Given this list of marker genes CXCR3, RHOF, FKBP5, CNGB1, NR2F2, HINFP, ARFGEF3, AK2, SYT7, ABHD5, UNC5B, CHRNE, FANCC, SEMA4G, BCL2L1, CALN1, SLC24A4, ATF5, ECE1, ATF7, TET3, IER5, RALY, C19orf47 (chromosome 19 open reading frame 47), BRWD1 (NCBI Gene Id 54146), GUCA1C, PPP1R18, EI24, ZCCHC3, RPL15, VWA1 (NCBI Gene Id 64856), CTNND1, DYNLT3, TMEM127, PDYN, VTI1A, PKNOX2, CBX4, CHRNB2, DDN, SPAG7, KCNA1, FCER1G, KIAA0319, RNF14, PBX2, ATXN7L3, SELENOW, PI4KB (phosphatidylinositol 4-kinase beta), RAB3A, USB1, CSNK1G1, IPCEF1, MAPK10, CNTNAP3, FOXRED1, ZNF346, HOXD13, CALU, MFN1, TMOD2, DMTN, P2RY4, AMFR, ARHGEF7, KDM4A, THRA, NAA40, PXN, HOXB9, SAMD4B, DPP8, RUFY2, CNTNAP3B, MAZ, PRDM11, SCRT2, TMEM121B, MYO1E, DCHS2, LRRTM2, CERT1, MKLN1 (muskelin 1), MMRN2, ATRN (NCBI Gene Id 8455), BRPF3, ZDHHC3, ARID3B (AT-rich interaction domain 3B), LAMB4, CANT1, MAF, TMEM43, PLEK2, LIPT2, MINK1, MEX3A, INO80D, CCDC68, NUP205, HCFC1R1, SHISA7 (NCBI Gene Id 729956), ZDHHC14, CLOCK, LZTS3, RBM14, TFE3, NR1I3, TSPAN33, RAD18, ZBTB7A, TNRC6A, BRAF, SH3PXD2A, PLEKHS1, CT55, TTC21A, CHD3, MKRN2, SRSF2 (NCBI Gene Id 6427), TAGLN2, BNC2, PCYOX1, ADO, PAMR1, PAF1, PDLIM5, SLC22A8, MXRA5, GRAP2, PRKD3, FZD2, PCDH7, MBD6, GRK6, SHISA6, RNF180, MIER3, UBE2D2, GRAMD1B (NCBI Gene Id 57476), CLIC5, REPS2 (RALBP1 associated Eps domain containing 2), ITGA7, KIF21B, ZBTB4, TRMT112, CDON, TNS1, EP300, RTN4RL2, CABP5, HDAC1, MAPK1, IFIT1B, C1QTNF7, PREP, SLC7A14, CXXC4 (CXXC finger protein 4), KDM2A, MOXD1 (NCBI Gene Id 26002), HUWE1, FADS2 (NCBI Gene Id 9415), ABCC10, SIPA1L3, SLC6A3, LY6D, XPO7, SASH3, NEUROG2, ZNF592, ZNF512, EGR3, CD209, SLC38A7, ZNF385A, PIK3R3, CHST3, MARK2 (microtubule affinity regulating kinase 2), CD177 (NCBI Gene Id 57126), KSR2, QKI, S100A14, RNF39, ZNF516, LGR6, PUM1, BTRC, TMEM69, ARPIN, P3R3URF-PIK3R3, DCAF7, ANAPC13, CHP1, SERF2 (NCBI Gene Id 88287), WAS, PABIR1, ZMYM3, PNOC, SLC4A7 (solute carrier family 4 member 7), PIP4K2B, TAOK3, SPRY4, GSTM5, COG6, SCAMP5, FYCO1, UBE2R2, JPH3 (NCBI Gene Id 57338), ARSI, NACC2, MARCKSL1, PATL1, TUB (TUB bipartite transcription factor), MAFG, WNT9B, ZIC3, RAB11FIP4, PTPN14, ASXL3, RASL10B, ELAVL2, LINGO1, BAZ2A, WDFY1, PRDM16, PYGB, LMOD1, STEAP3, CSDE1, DNAJA2, ZBTB20, OSBP, SDHC, DAPL1, SUCNR1, CORO2B, USP51, TSKU, SPOCK3, NRAS, MECP2, ELK1, TMEM131 (transmembrane protein 131), CCDC103 (NCBI Gene Id 388389), CFAP263, ZNF703, FKBP1A, CNOT2, CCDC178, OSBPL7, JPH4, SPRYD4, YY1AP1, MINPP1, PARS2, SYP, GPA33, SMARCD1, SDC3, FNBP1L, CNOT8, GIT1, IVL, SCNN1A, CPNE5, CD207, C19orf84, TPTE, PDXK, SPATA12, RHOC, RBM26, TMED4, PSMF1, GSDMA, RELL2, MFAP4, NECTIN1, PHACTR1, VAMP2, IGFBP4, ADCY9, JTB, EFNA3 (ephrin A3), BCAS3, here is a description of the gene set: Human Gene Set: MIR6780B_5P from publication Chen Y, Wang X (PMID 31504780) studied in species Homo sapiens Genes predicted to be targets of miRBase v22 microRNA hsa-miR-6780b-5p in miRDB v6.0 with MirTarget v4 prediction scores > 80 (high confidence targets).